Given this list of marker genes Pvr, Nectin3, Nectin1, Nectin4, Nectin2, Cadm3 (cell adhesion molecule 3), Cadm1, here is a description of the gene set: studied in species Mus musculus Mouse Gene Set: REACTOME_NECTIN_NECL_TRANS_HETERODIMERIZATION Nectin/Necl trans heterodimerization